Given this list of marker genes Uqcr10, Usp7, Setd7, Mmgt2, Tob2, Dmtf1, Klf13, Npm3, Arpc1b, Acp5, Psme1, Tmed10, Atp5mg, Ifitm10, Vps11, Emd, Map3k2, Tm2d1, Eif2s3x, Zcchc7, Lamtor4, Lgals8, Ccdc88b, Eif4e2, Kyat1, Rbm15b, Mrps36, Cd69, AW112010, Trip4, Pi4ka, Ubb, Tle5, Lgals3, Ppig, Ccl4, Pglyrp1, Jund, Slfn2, Med12, Cbx7 (NCBI Gene Id 69793), Exosc8, Pphln1, Reep5, Gimap9, Lyz2, Psmd4, Bcl7c, Vti1b, Gadd45gip1, Sf3b2, Smarcd1, Tra2a, Psmc4, Pigr (NCBI Gene Id 18703), Adrm1 (adhesion regulating molecule 1 26S proteasome ubiquitin receptor), Mindy3, Tomm22, Ppp1r11, Gsk3a, Naa10, Apbb1ip, Ssbp4, Mrps16, Zfp426, Sfswap, Usp24 (ubiquitin specific peptidase 24), Mtdh, Syf2, Mfap1a, Med27, Zfp592, Tom1l2, Arl6ip5 (NCBI Gene Id 93796), Tmem243, Rab11fip2, Scand1, Zbtb43, Klhl21, Rnf126, Ubl5, Mllt1, Tigit, Ik, Arel1, Fth1, Ap4s1 (NCBI Gene Id 11782), Cacybp, Fam89b, S100a11, S100a6, Pfdn5, Spcs2, Pfdn2, Tmem167, Aplp1 (NCBI Gene Id 11803), Slc5a6, Eps15l1, Cdk2ap2, Mrs2, Psmd7, Prrc2b, Sf3b4, Mdh1, Stmp1, Mfap1b, Rp9, Ranbp9, Swi5, Bicra, Supt6, Eif2s2, Zscan20, Dnajc3, Rgs1 (regulator of G-protein signaling 1), Ltb, Pop5, Bbc3, Entrep3, Eef1e1, Evl, Skap1, Itpr1, Mbp, Ddx28, Ppp1r35, Taf12, Plekhj1, Zfp335, Eno1b, Rpl34, Prr13, Mrpl41, Kcnab2, Gtf2i, B2m, Tcof1, Eme2, Timm13, Mien1, Fam50a, Cuta (cutA divalent cation tolerance homolog), Patl1, Eapp, Gabarap, Sipa1l1, Sertad2, Sf3b5, Zmym4, Bnip3l, Stx4a, Trir, Eef1d, Ppp1r12a, Fyb1, Zkscan17, Ddx23, Nlrc3, Anp32b, U2af1 (U2 small nuclear ribonucleoprotein auxiliary factor (U2AF) 1), Atf2, Sfr1, Pagr1a, Adss1, Lag3, Ino80e, Sap30l, Ncdn, Anxa11, Nsmce2 (NSE2/MMS21 homolog, SMC5-SMC6 complex SUMO ligase), Cpsf4, Ms4a4b, Glrx3, Lypla2, Zfp593, Srpk1, H2-K1, Ubr4, Lime1, Selenok (selenoprotein K), Rpl13a, Dbi, Cops6, Brk1, Calm3, Sod2, Card6, Smim20, Phc3, Higd2a, Cox11, H2-Eb1, Ccl3, Cotl1, Psmc5, Ndufb3, Sumo1, Nabp2 (nucleic acid binding protein 2), Socs1, Smad7, Rbm42, Ube2q2, Nkg7, Mrpl46 (mitochondrial ribosomal protein L46), Nop53, Zfhx2, Tmem176a, Fbl, Ifi203, Bag6, Tmem50a, Cox4i1 (NCBI Gene Id 12857), Tomm6, Ggact, Atp6v1g1, Hnrnpl, R3hdm1, Tmsb4x, Nop16, E130317F20Rik, Hdac7, Calm2, Adcy7, Znhit2, Epb41l2, Plaat3, Ndufb8, Ttyh3, Ndufa8, Ptprcap, Tbc1d10c, Cul3, Psma6, Cript, Pold4, Snrpb2, Pum2, Arid1a (NCBI Gene Id 93760), Siah2, Arpc4, Prpf38b, Wbp2, Tma7, Rwdd1, Ppm1a, Vcf1, Terf2, Zswim6, Wbp11, Oaz1, Chmp2a, Brd4, Krit1, Cxcr4, Bcl10, Wdr26, Lbh, Hars1, Naa38, Nck2, Coa6, Ccl5, B3gat3, Smc3, Ncoa5, Timm17b, Emc10, Abhd17b, Rab10os, Atp5mc2, Arhgdib, Sgf29, Dnajc2, Siglech, Psip1, Zfp865 (zinc finger protein 865), Stk24, Rhoh, Spn, Scaf1, Svbp, Setd5 (SET domain containing 5), Ftl1, Mbd1, Rbm26, Sdf4, Snrpc, Sp110 (Sp110 nuclear body protein), Abcb1b, Nr2c2ap, Tex10, Ndufaf3, Pak1ip1, Hopx, Cd3g, Lsm5, Dock8, Mllt10, Fxr2, Psenen, Plgrkt, Stim1, Skp1, Atrx, Erbin, Med11, Gzmk, Pak2, Cfdp1, AW554918, Ndufa12, Tnip1, Banf1, Nsmaf, Ldb1, Tmsb10, Arpc3, Zranb2, Tmem42, Ift20, Tmf1, Tpr, Gpd1l, Cd84, 2610005L07Rik, Capns1, Anp32e, Ptgr2 (prostaglandin reductase 2), Denr, Calm1, Syvn1, Tax1bp1, Rtf1 (NCBI Gene Id 99410), Thoc7, Lat, Rsbn1, Saysd1, Diaph1, Gar1, Slc25a36, Lamtor2, Ube2k, Snf8, Ubxn1, Pabpn1, Hk1 (hexokinase 1), Rab8a, Eif5b, Crybg2, Nfatc1, Rsf1, Kdm3b (NCBI Gene Id 76106), Bcl7a, Ints6, Cwc15, Grb2, Prickle3, Sra1, Ddi2, Lsm4, Ccnd2, Pcdh9, Frg1, Srsf5, Rabac1, Pebp1, Arhgap27, Purb, Zrsr2, H2-Ab1, Tmc8, Selenos, Disc1, Cfl1, Flii, H3f3b, Ube2j2, Elob, Atp6v0e, Fam117a, Wdr95, Hsp90b1, Sec61b, Ube2v1, Dynll2 (dynein light chain LC8-type 2), Zcrb1, Asxl2, Tmed9, Scp2, Pdap1, Ubr2, Map3k3, Baz1a, Snrpa, Esd, Mrps26, Atp5mc1, Nfkbib, Abracl, Trappc10, Susd3, Ube2m, Mndal, Thap3, Psmb10, Zfp644, Shisa5, Idnk, Grap2, Drap1, Ndufb10, Ndufa13, Cox8a, Zc3h15, H2aj, Pdcd5, Cyc1, Pfn1, Stx8, Ndufs6, Nab2, Mtfr1, Zc3h13 (zinc finger CCCH type containing 13), Slco2b1, Polr1h, Smarce1, Mrps24, Dctn3, Atp6v1f, Kif21b, Tacc1, Utp3, Pkp3, Ttc7, Sri, Ice1, Ptma, Ubxn4, Vasp, Mrpl43, C1d, Cenpq, Plekha1, Klk8, Crim1, Cycs (NCBI Gene Id 13063), Tmem238, Cirbp, Nasp, Rsrp1, Mcts1, Atp6v0c, Tnfrsf18, Ubald1, Ndufs7, Arf5, Ptpn18, Ppp1r18, Gpr174, Micos13, Prdx5, Tmem176b, Rhobtb2, Lsp1, Dazap1, Pttg1, Pnn, Zcchc17, Plod1, Zyg11b, Gpsm3, Cnot3, Fxyd5, Snrpd1, Gpx4, Hbs1l, Ubb-ps (NCBI Gene Id 624036), Rps16, Mycbp2, Kdm1b, Ciart, Anapc11, Pdhb, Dhx38, Npc2, Pelp1, Cyba, Hnrnpd, Clcf1, Ing1, Cxcr3, Ltn1, Pafah1b1, Sh2d2a, Chchd2, Lrch3, Ndufs3, Gng10, Fkbp3, Bcl9l, Dusp11, Bloc1s1, S100a13, 1810006J02Rik, Faim, Tspyl4, Aimp1, Clic1, Sh2d1a, Cenpx, Rnaset2b, Ddc, Malat1, Dynll1 (NCBI Gene Id 56455), Mrpl9, Secisbp2, Wbp4, Ptp4a3, Cd7, Llph, Cd37, Gnb2, Jarid2, Rnaseh2c, Tspan3, Prkca, Myl12a, H2-D1, Zc3h12a, Exosc5, Ube2q1, Mrpl30, Cd2, Tmem134, Polr2g (NCBI Gene Id 98133), Chmp1b, P2ry12, Ppp1r10, Atp13a1, Ogfod1, Bsg, Sdhc, Cd27 (NCBI Gene Id 21940), Dr1, Phf23, Ubqln4, Cox5a, Psmb8, Mdm4, Tnpo1, Ybx1, Pfdn6, Ssb (small RNA binding exonuclease protection factor La), Nol7, Hnrnpul1, Cdk11b, Psmb9, Bex3, 9330179D12Rik, Dgkz, Aurkaip1, Dctn6, Foxk1, Zfp444, Mrps12, Cst7, Tmem160, Gnptg, Nr1d2, Sub1, Psma7, Set, Txn2, Hnrnpa0, Rbm3os, Selenow, Ap2s1, Abhd17a, Ms4a6b, Rfx7, Synrg, Lsm2, Ddit3, Atox1, 1700113A16Rik, Bola3 (NCBI Gene Id 78653), Rab4b, Celsr1, Vgll4, Pdcd2, Krtcap2, Pigp, Ucp2, Gimap7, Mapk6, 1700097N02Rik, Sharpin, Dmac1, AI504432, Lsm12, Smap1, Mri1, here is a description of the gene set: from publication Tabula Muris Consortium (PMID 32669714) species: Mus musculus Mouse Gene Set: TABULA_MURIS_SENIS_MARROW_MATURE_ALPHA_BETA_T_CELL_AGEING